Given this list of marker genes GBP2, ABCA13, HIPK1, BCL2, TOX, ITGAV, KCTD18, PGRMC1, MIER1, MAGEB2, ELOC, GBP4, KLHL1, HSBP1, GPALPP1, RBBP6, SIAH1 (NCBI Gene Id 6477), ARHGAP5, GPATCH1, TRMT6, PJA2, PKLR, PPHLN1, FUNDC2, SERP1, PDLIM5, MTRR (5-methyltetrahydrofolate-homocysteine methyltransferase reductase), NF1, HNRNPF, TCF24, TMEM39A, TOR1AIP2, ADAMTS1, RARB, LUC7L3, JAZF1, TMEM30A, ZC2HC1A, KCNAB1, ASTN1, PATZ1, OXR1, CDC73, KL, CDK5RAP3, PPP1R2, ATG7, MYT1, HS6ST2 (heparan sulfate 6-O-sulfotransferase 2), SERBP1, RNF115, RNASE7, POGLUT3, GPC4, ZBBX, TMEM263, MINDY2, ABHD5 (abhydrolase domain containing 5, lysophosphatidic acid acyltransferase), DMAC1, ESRP1, CCNI2, here is a description of the gene set: Human Gene Set: MIR4637 Genes predicted to be targets of miRBase v22 microRNA hsa-miR-4637 in miRDB v6.0 with MirTarget v4 prediction scores > 80 (high confidence targets). studied in species Homo sapiens from publication Chen Y, Wang X (PMID 31504780)